Given this list of marker genes Erbb4, Rps27a, Ubb, here is a description of the gene set: part of: Signaling by ERBB4 studied in species Mus musculus Reactome Pathway: Downregulation of ERBB4 signaling electronically inferred by orthology from the curated human pathway This event has been computationally inferred from an event that has been demonstrated in another species.<p>The inference is based on the homology mapping from PANTHER. Briefly, reactions for which all involved PhysicalEntities (in input, output and catalyst) have a mapped orthologue/paralogue (for complexes at least 75% of components must have a mapping) are inferred to the other species.